The following is a description of a gene set: Despite efforts to profile prostate cancer, the genetic alterations and biological processes that correlate with the observed histological progression are unclear. Using laser-capture microdissection to isolate 101 cell populations, we have profiled prostate cancer progression from benign epithelium to metastatic disease. By analyzing expression signatures in the context of over 14,000 'molecular concepts', or sets of biologically connected genes, we generated an integrative model of progression. Molecular concepts that demarcate critical transitions in progression include protein biosynthesis, E26 transformation-specific (ETS) family transcriptional targets, androgen signaling and cell proliferation. Of note, relative to low-grade prostate cancer (Gleason pattern 3), high-grade cancer (Gleason pattern 4) shows an attenuated androgen signaling signature, similar to metastatic prostate cancer, which may reflect dedifferentiation and explain the clinical association of grade with prognosis. Taken together, these data show that analyzing gene expression signatures in the context of a compendium of molecular concepts is useful in understanding cancer biology. from publication Tomlins SA, Mehra R, Rhodes DR, Cao X, Wang L, Dhanasekaran SM, Kalyana-Sundaram S, Wei JT, Rubin MA, Pienta KJ, Shah RB, Chinnaiyan AM (PMID 17173048) species: Homo sapiens Human Gene Set: TOMLINS_METASTASIS_UP Top genes up-regulated in hormone refractory metastatic prostate cancer compared to localized prostate cancer., and this is the list of marker genes: RIMS2, DPYSL5, NEDD8, RHBDF2, GRK5, CAMKV, NAPB, IER5L, FAF1 (NCBI Gene Id 112268262), DVL3, CDKAL1, RAB6B, EVC, TUBA4A